Given this list of marker genes KCNQ2, SCN9A, HAPLN2, CNTN2 (contactin 2), SPTBN4, SPOCK1, KCNK4, KCNK2, KCNQ3, BIN1, SCN1A, SCN2B, ANK3, DAG1, DLG1, NFASC, SCN1B, SCN2A, MYOC, SCN8A, here is a description of the gene set: An axon part that is a gap in the myelin where voltage-gated sodium channels cluster and saltatory conduction is executed. Human Gene Set: GOCC_NODE_OF_RANVIER studied in species Homo sapiens